Given this list of marker genes RSPO4 (R-spondin 4), ITGA6, MSX2, PRICKLE1, MSX1, ITGB4, KRT84, HOXC13, FOXN1, FZD6, PRKAB1, here is a description of the gene set: Human Gene Set: GOBP_NAIL_DEVELOPMENT species: Homo sapiens The process whose specific outcome is the progression of a nail over time, from its formation to the mature structure. A nail is a horn-like envelope covering the outer end of a finger or toe, and consists of the nail plate, the nail matrix and the nail bed below it, and the grooves surrounding it.